Given this list of marker genes VAPA, ESD, BAIAP2, CDKN1C, CXCL17, MANF, PDLIM7, CDK2AP2, FIZ1, SAA1, BASP1, FURIN, FITM1, FOXO3 (NCBI Gene Id 2309), FAM131A, GSN, EIF4ENIF1, SLC23A2, NUS1, PLXNA2, BCAR3, SOD2, SLC43A3, GJB3, GDF15, GEMIN6, C1orf174, DOCK5, TULP4, CD302, GPX2, UBE2F, CCDC137, FMO2, CAPN2, MYL6B, CHI3L1, IGLL1, EPHB2, CDK18, GBX2, CLVS1, MT2A, ZC3H3, CFLAR, ZC3H10, CP, CXCL14, ANAPC16, TINAGL1, CTH, MAP3K6 (mitogen-activated protein kinase kinase kinase 6), PLAT, ADAMTSL4, SEC14L1, TXLNG (NCBI Gene Id 55787), PTHLH, ERLIN1, ITIH4, C14orf119, BANP, CPEB3, F7, TGM1, MT1E, GDPD1, SERPINA3, ABCB7, ALDH3A1, PTGES2, POP5, BIK, CTPS1, GCC1, ARPC5L, AREG, OXSR1, KLF9, SPHK1, CNTN6, SLPI, EIF5B, CARD10, PAPLN, MERTK, KCNK1, FASN, SKP1, CTSH, NUDCD1, PPP3R1, MGP, MASP2, SLC10A6, CDC42EP4, CARMIL1, RBM47, C22orf23, COL4A1, SAP30, FOSL1, LACTB, SPEF1, SLC2A1, PGS1, CYP4B1, ID1, EPHA2, PPP2R5B, ALAS1, LCN2, SORBS1, CKS2, CACNG3, ADGRL4, RAB3IP, GFPT2, ESRP2, HEXIM1, SLC7A6, IL34, PHAF1, SMG8, PDE4B (phosphodiesterase 4B), CPE, SFTPD, KRT8, PIGR, REXO4, GSTA5, MAT1A, CDRT4, FDX1, KLF12, IL33, SLC15A2, HOMER2, SNRK, LYVE1, RGCC, TIMP1, PRDX6, LRRK2, FABP6, SLC38A2, PNP, KMT5A (NCBI Gene Id 387893), TCN2, SCRIB, NAMPT, LRRC59, DAB1, KRT18, ACER2, ELF3, SPCS3, RIOK2, RAB21, PLK4, OSMR, MAFF, SVEP1, DUSP6, NPC2 (NPC intracellular cholesterol transporter 2), GSTA3, SPP1, SRPRB, BCL2L1, NPR3, HP, CFB, CHKA, SERINC3, FST, TLR4, TRIB1, DUSP16, TUT1, POU3F4, C1QTNF1, C3, LIMS2, KLF15, SLC35B1, NASP, PCGF6, MARCHF6, NOTCH1, ZBTB16, SPHK2, NKTR, DAPK1 (NCBI Gene Id 1612), FKBP5, RCAN2 (regulator of calcineurin 2), EFNB1, MTCH2, ABCC3, ADORA2B, RBM15, PGLYRP1, here is a description of the gene set: Genes down-regulated in comparison of lung tissue from wild type mice subjected to ozone for 0 h versus that from wild type mice subjected to ozone for 24 h. species: Homo sapiens from publication Bauer AK, Rondini EA, Hummel KA, Degraff LM, Walker C, Jedlicka AE, Kleeberger SR (PMID 21543283) We previously identified toll-like receptor 4 (Tlr4) as a candidate gene responsible for ozone (O3)-induced pulmonary hyperpermeability and inflammation. The objective of this study was to determine the mechanism through which TLR4 modulates O3-induced pulmonary responses and to utilize transcriptomics to determine TLR4 effector molecules. C3H/HeJ (HeJ; Tlr4 mutant) and C3H/HeOuJ (OuJ; Tlr4 normal), mice were exposed continuously to 0.3 ppm O3 or filtered air for 6, 24, 48 or 72 hr. Affymetrix Mouse430A_MOE gene arrays were used to analyze lung homogenates from HeJ and OuJ mice followed using a bioinformatic analysis. Inflammation was assessed by bronchoalveolar lavage and molecular analysis by ELISA, immunoblotting, and transcription factor activity. TLR4 signals through both the MYD88-dependent and independent pathways in OuJ mice, which involves MAP kinase activation, NF-kappaB, AP-1, and KC. Microarray analyses identifiedTLR4 responsive genes for strain and time in OuJ versus HeJ mice (p<0.05). One significantly upregulated cluster of genes in OuJ were the heat shock proteins (Hspa1b; Hsp70), Hsp90ab1). Furthermore, O3-induced expression of HSP70 protein was increased in OuJ compared to HeJ mice following 24-48 h O3. Moreover, BAL polymorphonuclear leukocytes (PMN) and total protein were significantly reduced in response to O3 in Hspa1a/Hspa1btm1Dix (Hsp70-/-) compared to Hsp70+/+ mice (p<0.05). TLR4 signaling (MYD88-dependent), ERK1/2, AP-1 activity, and KC protein content were also significantly reduced after O3 exposure in Hsp70-/- compared to Hsp70+/+ mice (p<0.05). These studies suggest that HSP70 is involved in the regulation of O3-induced lung inflammation through the TLR4 pathway and provide evidence that HSP70 is an endogenous in vivo TLR4 ligand. Human Gene Set: GSE20715_0H_VS_24H_OZONE_LUNG_DN